The following is a description of a gene set: Mouse Gene Set: GOBP_S_SHAPED_BODY_MORPHOGENESIS studied in species Mus musculus The process in which the S-shaped body is generated and organized. The S-shaped body is the successor of the comma-shaped body that contributes to the morphogenesis of the nephron., and this is the list of marker genes: Hes5, Pkd2, Hes1, Dspp, Wt1, Hey1, Lhx1, Pax8, Bmp4